The following is a description of a gene set: from publication Jardim-Perassi BV, Alexandre PA, Sonehara NM, de Paula-Junior R, Reis Júnior O, Fukumasu H, Chammas R, Coutinho LL, Zuccari DAPC (PMID 30700756) species: Mus musculus Gene sets differentially expressed in mouse cells, characterized by the tumor microenvironment between melatonin-treated and control samples in a xenograft model of triple-negative breast cancer using Balb/c athymic nude mice. Mouse Gene Set: JARDIM_PERASSI_TRIPLE_NEGATIVE_BREAST_CANCER_MOUSE_XENOGRAFT_MELATONIN_UP Balb/c athymic nude mice are unable to produce T-cells and are, therefore, immunodeficient. They are characterized by abnormal hair growth and defective development of the thymic epithelium. Insufficient information was provided in the publication regarding which specific Balb/c athymic nude mouse strain was used to generate the data., and this is the list of marker genes: Lce1j, Lce1e, Cldn5, Ccl12, Ctla2a, Cpxm1, Lce1f, Il36a, Apod, Slurp2, Calm4, Defb14, Ifit3, Lce6a, Mmp3, Tnfaip8l2, Ms4a4c, Gramd1c, Cstdc6, Hrnr, Gpx3, Ppfia4, Tmem37, Ccn5, Ereg, Serpinb12, Lce1h, Nherf2 (NCBI Gene Id 76520), Lce1g, Gngt2, Mgp, Ifi27l2a, Gng11, Krt1, Stfa3, Mdk, Egfl7, Slamf9, Wfdc21 (NCBI Gene Id 66107), Aif1, Klk9, Emcn, Sdcbp2